The following is a description of a gene set: species: Homo sapiens Cor pulmonale Right-sided heart failure resulting from chronic hypertension in the pulmonary arteries and right ventricle. Human Gene Set: HP_COR_PULMONALE, and this is the list of marker genes: FCGR2A, TGFB1, TPM3, ACTA1, BTK, HACD1, SREBF1, CFTR, FLNA, MAP3K20, SOX9, MYL2, ITGA7, SELENON, TPM2